The following is a description of a gene set: studied in species Mus musculus The circadian timing system coordinates many aspects of mammalian physiology and behavior in synchrony with the external light/dark cycle. These rhythms are driven by endogenous molecular clocks present in most body cells. Many clock outputs are transcriptional regulators, suggesting that clock genes primarily control physiology through indirect pathways. Here, we show that Krüppel-like factor 10 (KLF10) displays a robust circadian expression pattern in wild-type mouse liver but not in clock-deficient Bmal1 knockout mice. Consistently, the Klf10 promoter recruited the BMAL1 core clock protein and was transactivated by the CLOCK-BMAL1 heterodimer through a conserved E-box response element. Profiling the liver transcriptome from Klf10(-/-) mice identified 158 regulated genes with significant enrichment for transcripts involved in lipid and carbohydrate metabolism. Importantly, approximately 56% of these metabolic genes are clock controlled. Male Klf10(-/-) mice displayed postprandial and fasting hyperglycemia, a phenotype accompanied by a significant time-of-day-dependent upregulation of the gluconeogenic gene Pepck and increased hepatic glucose production. Consistently, functional data showed that the proximal Pepck promoter is repressed directly by KLF10. Klf10(-/-) females were normoglycemic but displayed higher plasma triglycerides. Correspondingly, rhythmic gene expression of components of the lipogenic pathway, including Srebp1c, Fas, and Elovl6, was altered in females. Collectively, these data establish KLF10 as a required circadian transcriptional regulator that links the molecular clock to energy metabolism in the liver. from publication Guillaumond F, Gréchez-Cassiau A, Subramaniam M, Brangolo S, Peteri-Brünback B, Staels B, Fiévet C, Spelsberg TC, Delaunay F, Teboul M (PMID 20385766) Genes down-regulated in the liver tissue from 10 week old male mice with KLF10 compared to wild-type littermates. Human Gene Set: GUILLAUMOND_KLF10_TARGETS_DN, and this is the list of marker genes: SRSF3, ENPEP, TXNIP, GPD1, OIT3, SLCO1B3, CLEC4F, CTNNB1, CYB5R3, TMSB4X, RPL7L1, VMP1, OSTC, CD36, PAPSS2, CHPT1, AK3, DERL2, SLC2A2, SEC61A1, CTSS (NCBI Gene Id 50653), RCAN1, ELOVL5, PSME4, OGT, UGT3A2, AQP9, VNN1, AACS, RTN4